Given this list of marker genes ATP5F1D, PSPH, AMT, ARG1, IRF6 (interferon regulatory factor 6), DNM1L, COX6B1, CTH, ALDH5A1, MMADHC, VARS2, MT-ND1, PCBD1, SLC6A18, FAH, ATP5F1A, LIPT2, ASL, NDUFB10, SCO1, PRDX1, FOCAD, PNPO, NOS3, SPR, TRMT10C, NFU1, MMAB, BCKDHB, LIG3, MTHFR, ABCD4, COX16, SLC36A2, LIPT1, USP53, LMBRD1 (NCBI Gene Id 55788), DTYMK, MTR, DMGDH, MT-ND6, TALDO1, IMPDH2, GCH1, CBS, COX10, PRODH, MT-ND2, MCEE, GLUL, NDUFA13, FTCD (formimidoyltransferase cyclodeaminase), SLC25A4 (NCBI Gene Id 7872), ATP5F1B, GNMT, UROC1, HCFC1, MTRR, NAGS, KARS1, OAT, SLC25A15, TCN2 (transcobalamin 2), AHCY, PET117, GUCY2D, MDH1, DLD, NR4A2, HAL, FBP1, MRPL3, TDO2, APP, PSAT1, CD320, NDUFS4, CA5A, ATP5MK, MIPEP, GLDC, TNFRSF11B (TNF receptor superfamily member 11b), PDHA1, OTC, MPO, ASS1, SLC30A10, GAMT, PDP1, MRPS2, PCCB, MTO1, NFS1, TFAM, OPA1, BCAT2, GCSH, MAT1A, PCCA, PDHX, SLC35C1, TEFM, MRPL39, MICOS13, UQCRC2, MCCC2, PPM1K, MT-TL1, SKIC3, NFE2L2, SLC6A19, ATP5F1E, SARDH, MMUT, TARS2, MPV17, MT-ND4, NGLY1, PTS, MTHFD1, MMAA, ATPAF2, IBA57, PC (NCBI Gene Id 5091), NDUFC2, TMEM70, ALDH18A1, GLYCTK, MRM2, POLG, HS6ST2, BCS1L, MICU1, FBXL4, HPD, ASPA, PLAU, COX5A, MT-TK, ASNS, QDPR, MT-ATP8, SUCLG1 (succinate-CoA ligase GDP/ADP-forming subunit alpha), KYNU, ADK, GLRX5, GLS, MMACHC, TMEM126B (transmembrane protein 126B), BOLA3, SLC6A20, MT-ATP6, MT-TV, AASS, LONP1, PHGDH, UPB1, TAT, MT-ND3 (mitochondrially encoded NADH:ubiquinone oxidoreductase core subunit 3), MT-TW, SLC7A7, MT-ND5, BCKDK, MCCC1, SLC19A1, CPS1, RRM2B, NADK2, MRPS14, PCK1, TYMP, GPHN, LYRM7 (LYR motif containing 7), PAH, BCKDHA, ALDH4A1, COQ9, COX8A (cytochrome c oxidase subunit 8A), SERAC1, SLC25A13, here is a description of the gene set: The presence of an abnormal decrease or increase of one or more amino acids in the blood circulation. studied in species Homo sapiens Abnormal circulating amino acid concentration Human Gene Set: HP_ABNORMAL_CIRCULATING_AMINO_ACID_CONCENTRATION